The following is a description of a gene set: Genes predicted to be targets of miRBase v22 microRNA hsa-miR-4752 in miRDB v6.0 with MirTarget v4 prediction scores > 80 (high confidence targets). from publication Chen Y, Wang X (PMID 31504780) species: Homo sapiens Human Gene Set: MIR4752, and this is the list of marker genes: BCOR, FMOD, TEP1, LRP6, MALT1, KCNMA1, ZBTB20, GLT8D2, BRWD3, CAMK2D, PASK, NQO1, TCAIM, CRYBA1, RABGAP1L, ZNF547, JPT1, EIF4E, TRAPPC8, MPHOSPH8, WIPF3, ATP10D, FBXO30, PJA1, COL19A1, GDF5, BECN1 (beclin 1), TMEM204, ITGAV, TMEM217, ZCCHC18, MYLK4, ZNF189, SESTD1, ANXA11 (NCBI Gene Id 311), SPPL3, TDRD15, AREL1, KCTD16, SLC2A13, ALCAM (NCBI Gene Id 214), RORA, PROSER1, DPT, SPMIP2, ZCCHC12, BTD, STX17, MZF1, CD160, GUCY1A2, KLHDC8A, E2F5, ADH5, FN1, NEDD4, ZKSCAN3, RAD23B, SLC39A13, C5orf15, PTPN21, DNAJC6, UNC5D, DHCR24 (24-dehydrocholesterol reductase), PPP4R3A, ZNF74, SCAI, SEMA6A, UBE2G1, ZNF33B, GDF10, PHIP, CETN2, MAP1B, APPL1, AGPAT3, CLVS2 (clavesin 2), DGKH, FIGN, SCLT1, FRG2, PDXK, ZNF135 (NCBI Gene Id 7694), TNFSF14, PICALM, ASB15